Given this list of marker genes Aldh3b2, Sult2a8, Aldh3b1, Adh5, Adh1, Akr1c18, Sult1b1, Aldh2, Sult2a1, Sult2a7, Sult2a3, Aldh1a7, Hao1, Sult2a4, Sult2a5, Adh7, Sult1e1, Sult2a6, Aldh1b1, Sult2a2, here is a description of the gene set: Mouse Gene Set: GOBP_PRIMARY_ALCOHOL_CATABOLIC_PROCESS The chemical reactions and pathways resulting in the breakdown of primary alcohols. A primary alcohol is any alcohol in which a hydroxy group, -OH, is attached to a saturated carbon atom which has either three hydrogen atoms attached to it or only one other carbon atom and two hydrogen atoms attached to it. studied in species Mus musculus